The following is a description of a gene set: Mouse Gene Set: GOBP_POST_EMBRYONIC_ANIMAL_MORPHOGENESIS The process, occurring after animal embryonic development, by which anatomical structures are generated and organized. studied in species Mus musculus, and this is the list of marker genes: Large1 (LARGE xylosyl- and glucuronyltransferase 1), Grk1, Crb1, Mir23a, Vps54, Nkx2-3, Atrx, Dscam, Enpp1, Gnas